The following is a description of a gene set: species: Homo sapiens Aplasia/Hypoplasia of the distal phalanges of the toes Absence or underdevelopment of the distal phalanges of the toes. Human Gene Set: HP_APLASIA_HYPOPLASIA_OF_THE_DISTAL_PHALANGES_OF_THE_TOES, and this is the list of marker genes: ARSL, VAC14, RIPK4, PIGF, ARID1B, MAP3K20, TBX5, PTHLH, TRPV4, KCNH1, FIG4, EOGT, HOXD13, NOG, KCNN3, GPC4, ROR2